Given this list of marker genes FEN1, ABAT, MCM6, MYOF, RAB31, SIAH2, GREB1, GINS3, PNRC1, SOX13, KIDINS220, NEMP1, TFF1, ABCG1, HSPB8, RAI14, SLC27A2, NAB2, MCM5, DTL, POLE2, RAB27B, SNX24, IGFBP4, CELSR2, VAMP2, PRSS23, PAPSS2, FHL2, SOX3, MICB, CXCL12, MCM4, FKBP8, SKP2, MCM2, ABCG4, GINS2, PXMP4, CDC6, CENPU, MCM10, SACS, TMPO, ZWILCH, RFC4, ADCY9, CCNE2, SGK3, TIPARP, SGK1, MED13L, CHRNA5, TIAM1, RRM1, RAB26, CYP24A1, PCNA, BTG3, GLA (NCBI Gene Id 2717), TSC22D3, OLFM1 (olfactomedin 1), TPBG, SLC16A1, ITPK1, RECQL, MT-ND5, CALCR, SLC39A8, SUSD4, DYNLT3, NCAPG2 (NCBI Gene Id 54892), MANEA, CDC25A, CAP2, SMC4, RET, HNRNPD, ATAD2, CA12, PLA2G2F, NDRG4, GRIN2B, here is a description of the gene set: Human Gene Set: STEIN_ESR1_TARGETS from publication Stein RA, Chang CY, Kazmin DA, Way J, Schroeder T, Wergin M, Dewhirst MW, McDonnell DP (PMID 18974123) Expression of estrogen-related receptor alpha (ERRalpha) has recently been shown to carry negative prognostic significance in breast and ovarian cancers. The specific role of this orphan nuclear receptor in tumor growth and progression, however, is yet to be fully understood. The significant homology between estrogen receptor alpha (ERalpha) and ERRalpha initially suggested that these receptors may have similar transcriptional targets. Using the well-characterized ERalpha-positive MCF-7 breast cancer cell line, we sought to gain a genome-wide picture of ERalpha-ERRalpha cross-talk using an unbiased microarray approach. In addition to generating a host of novel ERRalpha target genes, this study yielded the surprising result that most ERRalpha-regulated genes are unrelated to estrogen signaling. The relatively small number of genes regulated by both ERalpha and ERRalpha led us to expand our study to the more aggressive and less clinically treatable ERalpha-negative class of breast cancers. In this setting, we found that ERRalpha expression is required for the basal level of expression of many known and novel ERRalpha target genes. Introduction of a small interfering RNA directed to ERRalpha into the highly aggressive breast carcinoma MDA-MB-231 cell line dramatically reduced the migratory potential of these cells. Although stable knockdown of ERRalpha expression in MDA-MB-231 cells had no effect on in vitro cell proliferation, a significant reduction of tumor growth rate was observed when these cells were implanted as xenografts. Our results confirm a role for ERRalpha in breast cancer growth and highlight it as a potential therapeutic target for estrogen receptor-negative breast cancer. studied in species Homo sapiens Genes regulated by ESR1 in MCF-7 cells (breast cancer).